The following is a description of a gene set: This event has been computationally inferred from an event that has been demonstrated in another species.<p>The inference is based on the homology mapping from PANTHER. Briefly, reactions for which all involved PhysicalEntities (in input, output and catalyst) have a mapped orthologue/paralogue (for complexes at least 75% of components must have a mapping) are inferred to the other species. electronically inferred by orthology from the curated human pathway part of: Translation species: Mus musculus Reactome Pathway: Ribosome-associated quality control, and this is the list of marker genes: Psmd6, Rpl6, Rpl38, Rpl27a, Rpl29, Rps19, Psmd7, Psmb5, Psmc2, Psmb4 (proteasome (prosome, macropain) subunit, beta type 4), Rps15, Psma7, Rpl3, Rpl24, Ube2d1, Ascc3, Rpl23a, Fau, Rpl37a, Rps10, Psmc1, Rpl3l, Rps12, Psmd13, Rps17, Psmb6, Rps28, Rpl7, Rpl36al, Rps8, Rps20, Psmc6, Rpl36a, Rps27l, Rpl15, Rps13, Rps23, Rps25, Rpl13, Rps6, Rps26, Psma6, Rps24, Rpl39l (NCBI Gene Id 68172), Psmc5, Zfp598, Psmc3, Rps18, Rps27a, Psma2, Rps11, Rpl18, Psma1, Rps2, Psmc4, Rpl27, Rps4x, Rpl14, Rps3a1, Rps9, Klhdc10, Rpl9, Rps7, Rchy1, Rps5 (ribosomal protein S5), Rpl4, Psma5, Rpl37rt, Rpl12, Rpl19, Psma4, Psmb7, Rpl39, Psmd12, Psma3, Rpl11, Rpl37, Rpl26 (ribosomal protein L26), Ubb, Rplp2, Rpl18a, Psmd1